Given this list of marker genes ABCA12, PSMD6, ABCB1, ABCB8, ABCB6, ABCA9, RNF5, ABCD1, PSMD3, PSMD12 (proteasome 26S subunit, non-ATPase 12), PSMD2, PSMA1, ABCC3, ERLIN2, UBC, PSMA3, PSMC4, PEX3, ABCA2, APOA1, ABCA10, PSMA7, PSMA2, ABCC1, ABCA6, PSMC3, ABCB9 (ATP binding cassette subfamily B member 9), ABCC9, ABCB7, RPS27A, ABCB4, ERLIN1, DERL3, ABCA5, PSMD7, EIF2S3, PSMD14, ABCG8, ABCD3, EIF2S1, ERLEC1, PSMD13, EIF2S2, SEM1, ABCA8, KCNJ11, UBA52, PSMB5, ABCA7, ABCC2, ABCG5, PSMD8, SEL1L, ABCB5, PSMB4, PSMA6, PSMC5, PEX19, RNF185, DERL1, VCP, PSMA5, PSMC6, UBB, PSMB2, ABCA3, ADRM1, OS9, PSMD1, PSMD11, ABCC4, PSMC2, PSMA4, ABCC11, ABCA4, PSMB7, ABCG4, PSMB1, ABCC6, ABCD2, DERL2 (NCBI Gene Id 95558), ABCC10, ABCG1, ABCB10, ABCC5, ABCF1, PSMB6, PSMC1, PSMB3, CFTR, here is a description of the gene set: Reactome Pathway: ABC-family protein mediated transport part of: Transport of small molecules The ATP-binding cassette (ABC) superfamily of active transporters involves a large number of functionally diverse transmembrane proteins. They transport a variety of compounds through membranes against steep concentration gradients at the cost of ATP hydrolysis. These substrates include amino acids, lipids, inorganic ions, peptides, saccharides, peptides for antigen presentation, metals, drugs, and proteins. The ABC transporters not only move a variety of substrates into and out of the cell, but are also involved in intracellular compartmental transport. Energy derived from the hydrolysis of ATP is used to transport the substrate across the membrane against a concentration gradient. Human genome contains 48 ABC genes; 16 of these have a known function and 14 are associated with a defined human disease. species: Homo sapiens